The following is a description of a gene set: studied in species Mus musculus part of: TRIF (TICAM1)-mediated TLR4 signaling  electronically inferred by orthology from the curated human pathway This event has been computationally inferred from an event that has been demonstrated in another species.<p>The inference is based on the homology mapping from PANTHER. Briefly, reactions for which all involved PhysicalEntities (in input, output and catalyst) have a mapped orthologue/paralogue (for complexes at least 75% of components must have a mapping) are inferred to the other species. Reactome Pathway: TRIF-mediated programmed cell death, and this is the list of marker genes: Cd14, Tlr4, Casp8, Ticam2, Fadd, Ly96